The following is a description of a gene set: Human Gene Set: HP_BULL_S_EYE_MACULOPATHY Progressive maculopathy characterized by concentric regions of hyper- and hypo-pigmentation. studied in species Homo sapiens Bull's eye maculopathy, and this is the list of marker genes: HARS1, MFSD8, CRLS1, RAX2, TLCD3B (TLC domain containing 3B), ABCA4, RPGRIP1, IMPDH1, PROM1, VPS13B, TMCO1, RP2, MAK